The following is a description of a gene set: Human Gene Set: GSE3039_ALPHAALPHA_CD8_TCELL_VS_B2_BCELL_UP Genes up-regulated in CD8A T cells versus B2 B lymphocytes. Three innate (B1-B, NKT, CD8aaT cells) and adaptive (B2-B, CD4T, CD8abT cells) cell-types were sorted by FACS. Three biological replicates for NKT, CD4T, CD8aaT, CD8abT cells and two biological replicates for B1 and B2 cells were generated and the expression profiles were determined using Affymetrix Mu74Av2 chip. Comparisons between the sample groups allow the identification of genes differentially expressed between the innate and adaptive cell-types. from publication Yamagata T, Benoist C, Mathis D (PMID 16623764) species: Homo sapiens, and this is the list of marker genes: SPTB, DMBX1, NLRP5, GM2A, KHK, FABP3, IQGAP1, FAM241A, CEACAM21, HNRNPM, ST3GAL4, ADAM23, EPB41L3, CYTIP, NUP210, TSPYL4, FIS1, TAOK2, DAPL1, GPD1, CLXN (NCBI Gene Id 79645), SMC6 (structural maintenance of chromosomes 6), DGKG (NCBI Gene Id 1608), MAN2A1, SFT2D2, SPRYD3, RPGRIP1, DNAH11, MYADM, FLT3, LTB, MAPKAPK3, TSPAN13, SCARB1, FBXO10, ENPP2, CKLF, CD2, CCDC12, HMGCS2 (3-hydroxy-3-methylglutaryl-CoA synthase 2), TRABD, MINDY1, SORT1, DMKN, CAPN1, LIMD2, LECT2, TTC7A, LCE3B, DPY19L1, LRG1, IL6R, GTPBP8, IL27RA (NCBI Gene Id 9466), HP, NTNG1, SVIL, KLF3 (KLF transcription factor 3), ZKSCAN3, C2, PYGO2, PTPN6, ZNF804A, PABPC1L, SIGLEC10, HSBP1L1, NAT8L, KAZALD1, TESMIN, ASB2, TDRD7, GPR160, FBXL6, MOB3A, FLVCR1, DGKI, RP9, AVP, UBP1, RNASE3, RAD9A, AADAT, MON1A, CD5L, ANAPC16, KLHL25, RIN3, GATD1, AGPAT1, GPR137, SIDT2, SIRT7, SLC25A20, TSSC4, RBM45, FILIP1L, MRAS, NDUFB7, CD7, ACOT8, TMT1A, ZBTB7A, STAB2, PPARG (peroxisome proliferator activated receptor gamma), PBX2, SLC35C2, KCNJ9, ALDH1A2, ICOSLG, RIMS3, RASGRP2, HEMGN, FBXW2 (NCBI Gene Id 26190), L1CAM, TNFRSF18, EXTL1, KIAA0513, CDC40, JCHAIN, ATP1A1, RNF144B, PIKFYVE, ELMO2, MPO, SON, NHSL2, CFAP90, GP2, CAMP, GBA2 (glucosylceramidase beta 2), NLRX1, CTBP1, ACTR1A, NIN, NHERF4, SERP1, LIFR, KCNT1, OXLD1, PRR13, FFAR2, CKAP4, ORAI1, MAP3K3, ATRNL1, TNFRSF25, POU2AF1, MYL3, MDH2, CARNS1, KLF15, PLA2G7, SMARCD2, B4GALNT1, IRAG2, ARHGEF37, ADISSP, ABCC4, LBH, RASGRP4, TNFRSF13B, ZFAT (zinc finger and AT-hook domain containing), SND1, RSRP1, HLA-DMB, TMEM150B, CDKN2A, PTPN1, RTN3, LRTM2, PRAM1, APOC1, CYB561A3, GAK, HAAO, GTPBP6, SMPDL3A, DPP4, CHRNA7, SVIP, CD300A, CNBD2, WDR1, PLAC8 (placenta associated 8), SPN, PTX4, PDIA4, ARL6IP1, PMM1 (phosphomannomutase 1), CYRIA (CYFIP related Rac1 interactor A), MYCL, ASAP1, IFNGR1, P2RY13, SLFN12L, SLC52A2, MSN, MBD1, ICA1L, MYO1G